The following is a description of a gene set: Genes predicted to be targets of miRBase v22 microRNA hsa-miR-8079 in miRDB v6.0 with MirTarget v4 prediction scores > 80 (high confidence targets). from publication Chen Y, Wang X (PMID 31504780) Human Gene Set: MIR8079 species: Homo sapiens, and this is the list of marker genes: SGTB, CYRIA, HNRNPR, CLOCK, SOD1, PURG, AMMECR1L, TBRG1, TMEM199, MBL2, KRTAP9-9, LEPR, MEIOC, APP, ZNF250, MIA3, AJAP1, C11orf24 (chromosome 11 open reading frame 24), RPL34, RBM46, SEPTIN6, TRIM22 (tripartite motif containing 22), SMCO3, CNTN5, EAF1, MACIR, PRPS2, SGMS1, TMCC1, RAD54B, FSBP, KLRF1, SLFN5, MSL2, OPRK1, LCORL, SRSF8